The following is a description of a gene set: Any process that activates or increases the frequency, rate or extent of the inflammatory response. Mouse Gene Set: GOBP_POSITIVE_REGULATION_OF_INFLAMMATORY_RESPONSE studied in species Mus musculus, and this is the list of marker genes: Tnfsf4, Lpl, Cebpb, Fcgr3, Gm12250, Stat5b, Alox5ap, Tlr6, Ninj1, Adora3, Il16, Ffar3, Ets1, C2cd4a, Vamp8, Ptgs2, Nppa (NCBI Gene Id 230899), Tgfb1, Zdhhc5, Nlrp1b (NLR family, pyrin domain containing 1B), Ccn4, Park7 (Parkinson disease (autosomal recessive, early onset) 7), Cd28, Casp3, Snca, Nmi, Tnfrsf1a, Cd81, Gbp2, Zp3, Stap1, Adam8, S100a9, Abcc1, Ighg1, Adora2b, Ccl1, Il17ra, Pdcd4, Fem1a, Ccl24, Lgals2, Fcgr1, S100a8, Ptger3, Pla2g3, Pycard, Trem2, Camk2n1, Mefv, Osm, Nlrp10, C2cd4b, Tafa3, Ctss, Ldlr, Kars1, Fabp4, Nlrp1a, H2-T23, Gprc5b, Napepld, Lgals1, Pde5a, Ttbk1, Nupr1, Nkg7, Tnfrsf11a (NCBI Gene Id 21934), Hyal2, Ifng, Il33, Sucnr1, Stat5a, Gbp5, Ctsc, Pde2a, Kcnn4, Fcer1g, Rps19, Tnfsf18, Cebpa, Il1rl1, Nlrp3, Cd47, Il1b, Il6, Prkca, Ccl3, App, Tlr2, Nfkbia, Tlr4, Nlrp6, Aoc3 (NCBI Gene Id 11754), Npy5r, Lilra5, Clock, Gpr4 (NCBI Gene Id 319197), Tnf, Tnip1, Ido1, Snx4, Ccr5, Tac1, Ptger4, Lrrk2, Casp1, Cnr1, Aim2 (NCBI Gene Id 383619), Ighg2b, Ccr7, Btk, Il18, Casp4, Setd4, Il17rb, Ccl5, Trpv4, Ccr2, Ripk1, Ifi35, Csf1r, Cx3cl1, Tslp, Tnfsf11, Pik3cg, Zbp1, Fcer1a, Cd24a, Gbp2b, Gbp3, Ffar2, Casp12, Grn, Lbp, Gpsm3, Mdk, Serpine1, Nfkbiz, Ddt, Mmp8, Wnt5a, Tradd, Zdhhc9, Lta, C3, Htr2a, Map3k8, Plcg2, Gsdmd, Dhx9